Given this list of marker genes Adcy6, Gng12, Ywhaq, Cald1, Rxfp2, Prkcz, Slc8a1, Rgs4, Igfbp2, Ramp1, Gngt1, Nos3, Gng2, Nfkb1, Rgs5, Atf4, Gng11, Prkca, Gabpa, Cnn1, Atp2a2, Camk2b, Sp1, Ryr1 (NCBI Gene Id 20190), Rgs2, Plcg1, Guca2a, Atf6b, Igfbp3, Prkar1a, Grk5, Adcy5, Pkia, Actb, Prkar1b, Rgs6, Rgs10, Itpr3, Rgs18, Plcg2, Ramp3, Myl4, Gnas, Gabpb1, Prkcb, Prkcg, Camk2a, Ywhae, Pkig, Itpr2, Prkcq, Camk2g, Lpar1, Adcy7, Rxfp1, Gnb3, Pde4b, Rln1, Rgs16, Oxtr, Prkar2a, Dgkz, Gng5, Gnaq, Atp2a3, Rgs20, Gpr182, Mylk2, Atf2 (activating transcription factor 2), Crcp, Myl2, Rgs17, Calm3, Rgs14, Adcy8, Ywhab, Il6, Rgs3, Oxt, Ramp2, Atf1, Gnb1, Crhr1, Adcy4, Adm, Prkd1, Gnb4, Ackr3, Ryr3, Jun, Igfbp4, Nos1, Gnb5, Igfbp6, Ywhah (tyrosine 3-monooxygenase/tryptophan 5-monooxygenase activation protein, eta polypeptide), Adcy9, Adcy2, Plcd1, Sfn, Rgs7, Gng8, Prkch, Gng13, Calca, Atf3, Ryr2, Rgs19, Grk6 (G protein-coupled receptor kinase 6), Guca2b, Adcy3, Grk4 (NCBI Gene Id 80675), Camk2d, Gng7, Plcb3 (phospholipase C, beta 3), Igfbp1, Ets2, Pkib, Ywhaz, Gng3, Fos, Actg1, Prkcd, Prkce, Prkar2b, Gsto1, Cacnb3, Gja1, Igfbp5, Il1b, Prkacb, Maff, Rgs1, Crh, Itpr1, Rgs9, Pde4d, Corin, Creb3, Actc1, Ywhag, Gucy1a1, Rgs11, Atf5 (NCBI Gene Id 80874), Creb1, Gng4, Arrb1, Arrb2, Acta1, Adcy1, here is a description of the gene set: Myometrial relaxation and contraction pathways species: Mus musculus Mouse Gene Set: WP_MYOMETRIAL_RELAXATION_AND_CONTRACTION_PATHWAYS